Given this list of marker genes SLC25A53, SLC25A52, SLC25A51, SLC25A47, SLC25A17, P2RX7, here is a description of the gene set: Human Gene Set: GOBP_NAD_TRANSPORT studied in species Homo sapiens The directed movement of nicotinamide adenine dinucleotide into, out of or within a cell, or between cells, by means of some agent such as a transporter or pore; transport may be of either the oxidized form, NAD, or the reduced form, NADH.